The following is a description of a gene set: Dynamic structural changes in centromeric DNA. Mouse Gene Set: GOBP_CHROMATIN_REMODELING_AT_CENTROMERE studied in species Mus musculus, and this is the list of marker genes: Mis18a, Cenpp, Hjurp, Cenpi, Oip5, Nasp, Cenpn, Itgb3bp, Cenpa